Given this list of marker genes HEBP2, NAA50, IGLL1, MAN2A2, PLEC, TAGLN3, SEL1L3 (SEL1L family member 3), MZT2B, IL36RN, GTF2F1 (NCBI Gene Id 2962), SEMA4F, BCL6, LEPROTL1, LGI4, GIPC2, CHSY3, COPZ2, MGST1, S100A10, GPATCH3, PGD, NPHP3, SH3RF1, UBTD1, POLR1A, SELE, MOK, NME2, FOXD2, RABL6, ATP8B2, SNCB, HADHA, NPAS1, MLF2, ISX, GSG1L, MRPS6, FSHB, RNF207, RIN2, CYP1B1, PTPA (protein phosphatase 2 phosphatase activator), CFAP298, ANXA1, R3HDM4, LSM4, CAMK1, MEDAG, NT5E, RWDD2A, POU5F2, GUCA1A, PLPP3 (phospholipid phosphatase 3), CTHRC1, LRIG1, COA4, APBB1, LDB3, CD163, PTMS, NXT1, IL18, LSP1, RPS5, BMP1, MRC2, PGLS, BPIFB1, GPX8, STMND1, ANXA6, KCNK6, TRAM2 (NCBI Gene Id 9697), FAM53B, MARK1, CMTM5 (NCBI Gene Id 116173), AMTN, PPP1R14B, CYP17A1, CNP, SLC25A4, NEUROD6, NEURL2, CAPN10, RERG, AP5Z1, MICAL2, SEC61B, FLT1, CD248, IL6R, BCORL1, TPRG1, CA12, ITPRIPL1, RPUSD3, KANK3 (NCBI Gene Id 256949), EFTUD2, EMC8, COL15A1, TK1, C6orf132, CBX5, EVPL (envoplakin), PARK7, FSHR, CES3, MRPL11, ACTA1, ARL2, INSM2, RBFA, CXCL11, FLNC, TMC8 (transmembrane channel like 8), SCARF2, USP43, MTA1, SOD1, CRIP1, ZNF428, TRNP1, SLC52A3 (solute carrier family 52 member 3), GCHFR, SLC1A7, MAD1L1, NRAP, MINAR1 (membrane integral NOTCH2 associated receptor 1), GOT2 (NCBI Gene Id 2806), CREB5, ARK2N, REG3G, MRPL54, OVOL2, TMEM270, NGFR, FNDC9, FHL2, GLIPR1L1, SALL1, KIAA1549L, PRSS50, LIN28B, ELAVL3, PTK7, TDRP, PAK3, HTR5A, CCDC73, ZNF558, TFF2 (trefoil factor 2), ADORA2A, PAQR8, PPP1R14D, SPTBN2, SYCN, IQCH, EEF1G, KCNC2, HRAS, CCSER1, ITGA2B, THSD7B, ZCCHC3, C4orf36, EIF3K, SEMA3F, PABPC1, CABIN1, LGALS12, HSP90AB1, LMNTD1, TNIP2, KRTAP4-12, NUP210, ICA1L, CHRNA9, GNAT2, NELL2, RBFOX2, KLHL9, ZSWIM9, ERICH2, LYZL6, NAGS, NPHS2 (NPHS2 stomatin family member, podocin), CHRM4, KCTD11, DPYS, TSPAN9, NEFH, C1QL3, FAM171A2, SHC3, ADH5, MYL7, CASTOR1, MFSD13A, SALL4, here is a description of the gene set: Human Gene Set: GSE3203_WT_VS_IFNAR1_KO_INFLUENZA_INFECTED_LN_BCELL_DN studied in species Homo sapiens Influenza virus infection-induced gene expression changes of regional B cells are mediated at least in part through type I Interferon: Our objective is to determine whether the influenza virus-infection induced gene expression changes in regional lymph node B cells are facilitated at least in part through type I interferon. Our specific aim is to compare the gene expression profile of highly FACS-purified B cells in the regional lymph nodes of wildtype and IFNR-/- mice prior to and 48h following infection with influenza virus infection and to contrast this expression profile with that of FACS-purified wildtype B cells activated in vitro with IFN-beta +/- anti-CD86 for 12h. from publication Chang WL, Coro ES, Rau FC, Xiao Y, Erle DJ, Baumgarth N (PMID 17237394) Genes down-regulated in lymph node B lymphocytes with influenza infection: wildtype versus IFNAR1 knockout.